The following is a description of a gene set: studied in species Mus musculus Mouse Gene Set: GOBP_MRNA_PROCESSING Any process involved in the conversion of a primary mRNA transcript into one or more mature mRNA(s) prior to translation into polypeptide., and this is the list of marker genes: Supt6, Lgals3, Tent2, Tra2b, Bcas2, Ddx39a, Sfswap, Snrpb, Snrpc, Ppp1r8, Aqr, Scaf8 (NCBI Gene Id 77962), Snw1, Nsrp1, Clasrp, Ncbp2 (NCBI Gene Id 98015), Ddx47, Exosc10, Gpatch8, Nol3 (nucleolar protein 3 (apoptosis repressor with CARD domain), NCBI Gene Id 78688), Rbpms2, Sart1, Snrpe, Thoc1, Wdr83, Rbm25, Zfp326, Rbm4, Hnrnpc, A1cf, Arvcf, Hnrnpa2b1, Upf3a, Snrpert, Sf3b2, Ppp4r2 (protein phosphatase 4, regulatory subunit 2), Srsf3, Mettl16, Srpk2, Gemin2, Slirp, Fastkd5, Slu7, Thoc3, Zfp64, Trmt61a, Acin1, Rbm10, Adarb2, Yju2, Prmt5, Cdk13, Zrsr2, Lsm6, Dhx38, Snrnp200, Luc7l, Prmt7, Prpf6, Rbm41 (RNA binding motif protein 41), Zcchc8, Rnasel, Snrpb2, Snrpf, Cwc22rt4, Slc39a5, Cwc22rt5, Zranb2, Cdc5l, Cactin, Luc7l2 (NCBI Gene Id 75005), Papolb (poly (A) polymerase beta (testis specific)), Rprd2, Cdc5lrt6, Zfp36l1, Ncbp1, Tut1, Rbm11, Clns1a, Cpsf2, Cpsf7, Dcps, Pus1, Rbm5, Paxbp1, Paf1, Cwc25, Adam3, Hnrnpa1, Usp49, Eif1, Ncbp3, Ern2, Zmat2, Psip1, Prpf3, Trub1 (TruB pseudouridine (psi) synthase family member 1), Mtpap, Eftud2, Dus3l, Yju2b, Pcbp1, Nrde2, Snrnp25, Prpf40a, Khsrp, Mbnl1, Rbm8a, Alkbh5, Tcerg1, Rnf113a1, Rbm3, Rbbp6, Celf5, Cdk9, Sap18, Ctnnbl1, Srsf10, Tsen15, Strap, Khdrbs3, Fmr1, Upf1, Phrf1, Bud13, Pus7l (pseudouridylate synthase 7-like), Ppwd1, Cstf3, Srsf1, Rbmy, Xab2 (XPA binding protein 2), Rbfox2, Mfap1a, Cwc22rt6, Aff2, Cenatac, Sf3b4, Ssu72, Ddx23, Cdc40, Rbm14, Wdr33, Snrpn, Pus7, Myod1, Son, Lsm8, Rbmyf9, Rbfox1, Rbmxl1, Pabpc2, Lsm10, Armc7, Cwc22rt7, Fbxo24 (NCBI Gene Id 71176), Sf3b6, Sf3a3, Srsf5, Ybx1, Zpr1, Prpf4b, Lsm11, Iws1, Csdc2, Zcrb1, Obi1, Srrt, Cdc5lrt7, Rbm20, Papolg, Cdc5lrt5, Rbfox3, Pan2, Cpsf3, Lsm4, Jmjd6, Cwc22rt2, Akap8l, Cd2bp2, Zc3h14, Rbm44, Ythdc1, Tent4b, Lsm2, Sf1, Sugp1, Prmt9, Tardbp, Dnajc17, Srpk3, Gm7324, Ints15, Pcbp4, Rpusd3, Safb, Kin, Setx, Gemin6, Thumpd2, Akr1c6, Cwc22rt3, Nova1, Rbm6, Rbm15, Rest, Ddx5, Snrpd1, Kat8, Srsf12, Ess2, Srsf4, Pabpn1, Cdc73, Nudt21, Rbmx2, Apobec2, Gemin8, Larp7, Hnrnpa3, Celf6, Akap17b, Lsm5, Chd8, Snrnp70, Wbp11, Magoh, Thoc7, Zc3h3, Ddx46, Prdx6b, Bud31, Snrpa, Rbm7, Trmt2a, Srek1ip1, Txnl4b (NCBI Gene Id 234723), Cpsf4, Magohb, BC005624, Eif4a3, Sf3b3, Ppil1, Syf2, Rnpc3, Crnkl1, Gemin7, Scaf4, Pabpc1, Adar, Srsf2, Thoc5, Usp39, Rpusd4, Sf3a2, Clp1, Dyrk1a, Raly, Ddx42, Esrp1, Hnrnpf, Ivns1abp, Scaf1, Hnrnpul2, Prpf39, Prpf8, Tfip11, Rsrp1, Prkrip1, Rbm15b, Ddx20 (DEAD box helicase 20), Dhx8, Tia1, Hnrnpk, Xrn2, Apobec4, Ddx17, Rbm28, Ppih, Cstf1, Ddx1, Dhx36, Ramac, Gemin6-ps, Hnrnph1, Fra10ac1, Alyref, Habp4, Ncl, Celf2, C1qbp (complement component 1, q subcomponent binding protein), Dhx15, Htatsf1, Srsf7, Hnrnpll, Arl6ip4 (ADP-ribosylation factor-like 6 interacting protein 4), Leo1, Cwf19l2, Hnrnpul1, Gemin4, Zmat5, Hsf1, Wbp4 (NCBI Gene Id 22380), Cdc5lrt4, Rbm17, Virma, Nono, Celf3, Ptcd2, Ptbp2, Frg1, Srsf9, Lsm3, Snrnp48, Ecd, Malat1, Cpsf1, Mblac1, Sde2, Rprd1a, Ttf2, Sf3b1, Brdt, Ilf3, Prpf38b, Cirbp, Rbpms, Rbm39, Isy1, Trmt10c, Srsf6, Pnpt1, Cdc5lrt9, Luc7l3, Mbnl3, Snrpd2, Rbm4b, Cstf2t, Wdr77, Esrp2, Gpkow, Tra2a, U2af1, Celf4, Scaf11, U2af1l4, Ppil3, Phf5a, Snrpa1, Dhx9, Sltm, Gcfc2, Pqbp1, Cstf2, U2af2, Scnm1, Snrnp35, Usp4, Mettl14, Aar2, Tssc4, Hnrnpm, Coil, Hspa8, Puf60, Alyref2, Ddx39b, Ahcyl1, Sympk, Srrm4, Ubl5 (ubiquitin-like 5), Pcif1, Cwc22rt1, Srrm1, Ccar2, Safb2, Celf1, Cmtr2, Rnf113a2, Adarb1, Srrm2, Cdc5lrt1, Ptbp1, Srpk1, Lsm1, Zc3h13, Pan3, Snrnp27, Cwf19l1, Qki, Elavl4 (NCBI Gene Id 15572), Cir1, Cnot6l, Thoc2 (NCBI Gene Id 434773), Arglu1, Tsen2, Fip1l1 (factor interacting with PAPOLA and CPSF1), Ddx41, Cdc5lrt10 (NCBI Gene Id 668216), Sf3a1, Casc3, Prpf19, Prdx6, Rbm22, Sart3, Rngtt, Txnl4a, Rprd1b, Nsun2, Arb2a, Khdrbs2, Papola, Mtrex, Rbm47, Lsm7, Thrap3, Rbmyf1, Rrp1b, Plrg1, Wtap (NCBI Gene Id 77275), Aicda, Rbmyf6, Ptbp3, Ppil2, Trmt6, Smn1, Sfpq, Tsen54, Sap18b, Cwc22, Prpf38a, Slbp, Prkaca, Rnmt, Snrpg, Zbtb7a, Hnrnpu, Snip1, Hdac7, Rbmxl2, Dazap1 (DAZ associated protein 1), Larp7-ps, Angel2, Cript, Ccnb1, Cwc15, Nova2, Cpeb1, Rsrc1, Ppie, Sugp2, Ern1, Cdk12, Rbm48, Myg1, Syncrip, Smu1, Rbmyf3 (NCBI Gene Id 100042881), Khdc4, Smndc1, Prpf40b, Cpsf6, Tbrg4, Plcb1 (NCBI Gene Id 98861), Trub2, Pcf11, Upf3b, Rbm8a2, Eif4a3l1, Rbm38, Prpf4, Ik, Srsf8, Zfp830, Snrpd3, Mbnl2, Tdrd6, Mettl3, Srek1, Snu13, Tent4a, Apobec1, Nup98, Prpf18, Khdrbs1, Tsen34, Zfp473, Pnn, Npm1, Cbll1, Gpatch1, Grsf1, Dhx40, Snrnp40, Eif4a3l2, Ubl5b, Hmx2, Dhx16, Rbmx, Cdc5lrt8, Sf3b5, Lmntd2, Hnrnpl, Mfap1b, Rnps1 (RNA binding protein with serine rich domain 1), Rbm42, Cmtr1, Rpusd2, Pde12, Fam50a, Prpf31, Thoc6 (THO complex 6), Gemin5, Rbm24, Dbr1